The following is a description of a gene set: The process whose specific outcome is the progression of the axial mesoderm over time, from its formation to the mature structure. The axial mesoderm includes the prechordal mesoderm and the chordamesoderm. It gives rise to the prechordal plate and to the notochord. Human Gene Set: GOBP_AXIAL_MESODERM_DEVELOPMENT studied in species Homo sapiens, and this is the list of marker genes: AXIN1, FOXH1, EPHA2, ZIC3, NOG, POGLUT1, EPB41L5, NODAL, RPL38